The following is a description of a gene set: Genes down-regulated in LNCaP cells (prostate cancer) in response to synthetic androgen R1881. species: Homo sapiens from publication Nelson PS, Clegg N, Arnold H, Ferguson C, Bonham M, White J, Hood L, Lin B (PMID 12185249) Human Gene Set: NELSON_RESPONSE_TO_ANDROGEN_DN The human prostate gland is an important target organ of androgenic hormones. Testosterone and dihydrotestosterone interact with the androgen receptor to regulate vital aspects of prostate growth and function including cellular proliferation, differentiation, apoptosis, metabolism, and secretory activity. Our objective in this study was to characterize the temporal program of transcription that reflects the cellular response to androgens and to identify specific androgen-regulated genes (ARGs) or gene networks that participate in these responses. We used cDNA microarrays representing about 20,000 distinct human genes to profile androgen-responsive transcripts in the LNCaP adenocarcinoma cell line and identified genes with transcript alterations more than 3-fold. Of these, 103 encode proteins with described functional roles, and 43 represent transcripts that have yet to be characterized. Temporal gene expression profiles grouped the ARGs into four distinct cohorts. Five uncharacterized ARGs demonstrated exclusive or high expression levels in the prostate relative to other tissues studied. A search of available DNA sequence upstream of 28 ARGs identified 25 with homology to the androgen response-element consensus-binding motif. These results identify previously uncharacterized and unsuspected genes whose expression levels are directly or indirectly regulated by androgens; further, they provide a comprehensive temporal view of the transcriptional program of human androgen-responsive cells., and this is the list of marker genes: DPH1, BARD1, PIK3R3 (phosphoinositide-3-kinase regulatory subunit 3), BCHE, MMP16, SLC29A1, CDK8, DDC, SCNN1A, SERPINI1, CTBP1 (C-terminal binding protein 1), FN1, PRKD1, TULP4, MYC, ST7, SDC4